The following is a description of a gene set: Human Gene Set: GOMF_TELOMERIC_DNA_BINDING species: Homo sapiens Binding to a telomere, a specific structure at the end of a linear chromosome required for the integrity and maintenance of the end., and this is the list of marker genes: TERF2, SMG5, TEN1, HNRNPA2B1, WRN, TP53BP1, HNRNPD, SMG6, UPF3A, RPA2, ZBTB48 (NCBI Gene Id 3104), SMG7, APEX1, NABP2, SMG1, ACD, UPF1, TINF2, PIF1, CTC1 (NCBI Gene Id 80169), PURA (purine rich element binding protein A), ZBTB10, TERF2IP, KDM1A, POT1, XRCC6, NCL, XRCC5, TELO2, BLM, RPA4, TERF1, HMBOX1, UPF2 (UPF2 regulator of nonsense mediated mRNA decay), RPA1, TERT, STN1, RAD50, HNRNPA1